Given this list of marker genes Cxcr1, Cxcr6, A2m, Cxcr3, Ackr3, Cxcr2, Hmgb1, here is a description of the gene set: Mouse Gene Set: GOMF_C_X_C_CHEMOKINE_BINDING species: Mus musculus Binding to a C-X-C chemokine; C-X-C chemokines have a single amino acid between the first two cysteines of the characteristic four cysteine motif.